Given this list of marker genes Vkorc1l1, Rrm2b, Rrm2, Rrm1, Vkorc1, here is a description of the gene set: studied in species Mus musculus Mouse Gene Set: GOMF_OXIDOREDUCTASE_ACTIVITY_ACTING_ON_CH_OR_CH2_GROUPS_DISULFIDE_AS_ACCEPTOR Catalysis of an oxidation-reduction (redox) reaction in which a CH2 group acts as a hydrogen or electron donor and reduces a disulfide group.